The following is a description of a gene set: This event has been computationally inferred from an event that has been demonstrated in another species.<p>The inference is based on the homology mapping from PANTHER. Briefly, reactions for which all involved PhysicalEntities (in input, output and catalyst) have a mapped orthologue/paralogue (for complexes at least 75% of components must have a mapping) are inferred to the other species. part of: Complement cascade electronically inferred by orthology from the curated human pathway Reactome Pathway: Regulation of Complement cascade species: Mus musculus, and this is the list of marker genes: C5ar1, Elane, Hc, C1s2, C1ra, Cfi, Cd46, Cd81, Cpn2, C5ar2, Vtn, C9, C6, C3, C3ar1, Serping1, C8a, Cd55, C1qb, Igll1, C2, Cfp, Cr1l, Cd19, C8g, C4b, Cpn1, C1qc, C1qa, F2